Given this list of marker genes Timm9, Ttc14, Klhl15, Pigs, Lmnb2, Dpysl3, Ssh2, Zfp516, Eloc, Shh, Bclaf1, Dhx37, Timd5, Ptbp2, Stx16 (NCBI Gene Id 99409), Fam167a, Med9, Zfp236, Pramel5, Nova1, Pdzrn4, Gpatch2l, Grhl2, Slc17a2, Kif26a, Dixdc1, Zbed5, Foxp2, Eif1b, Mapk1, Nlk, Pcdh10, Mrpl20, Rgs7bp, Chmp3, Garem1, Mme (NCBI Gene Id 97098), Mia3, Scn7a, Adamts5, Pdp2, Cfap36 (NCBI Gene Id 66744), Emc1, Sall1, Nfatc2, Tti2, Tln2, Mideas, Dnajb14, Pnn, Acvr2b, Polr2d, Fam3c, Twist1, Adgre4, Cyp2e1, Sox5, Lsm11, Tut4, Magee2, Calu, Lrrfip1, Tbc1d30, Ccdc71l, Cbll1, Thsd7a, Med28, Slc6a1, Lin28b, Slco1a1, Arhgef11, Rlim (ring finger protein, LIM domain interacting), Tmem164, Kdm5a, Dazap2, Kcna6, Psip1 (PC4 and SFRS1 interacting protein 1), Ep300, Bri3, Cnot10, Cldn10, Zfyve1, Mex3c, G3bp2, Sppl3, Chd1, Fam91a1, Klf17, Kdm7a, Lemd3, Usp9x, Foxo3, Glcci1, Nacc2, Nras, Rictor, Dcun1d4, Ube2d2a, Daam1, Rasa1, Zdhhc20, Pspc1, Mycbp2, Lipm, Atxn1, Mef2a, Hbegf (NCBI Gene Id 225370), Ppp2r5e, Ark2n, Rras2, Hmga2, Larp4, Dnmt3a, Ehhadh, Klhl11, Prss46, Pramel4, Tmem161b, Zfp874b, Cc2d1b, Hapln1, Gdf5, Sema6a, Pramel61, Sgk3, Nin, Phka1, Nrep, Tjap1, Rad54l2, Dusp9, Osbpl8, Brwd1, Btc, Tmeff1, Rbak (RB-associated KRAB zinc finger), here is a description of the gene set: Mouse Gene Set: MIR_212_3P species: Mus musculus Genes predicted to be targets of miRBase v22 microRNA mmu_miR_212_3p in miRDB v6.0 with MirTarget v4 prediction scores > 80 (high confidence targets). from publication Chen Y, Wang X (PMID 31504780)